The following is a description of a gene set: from publication Lund R, Aittokallio T, Nevalainen O, Lahesmaa R (PMID 14607935) Th1 and Th2 cells arise from a common precursor cell in response to triggering through the TCR and cytokine receptors for IL-12 or IL-4. This leads to activation of complex signaling pathways, which are not known in detail. Disturbances in the balance between type 1 and type 2 responses can lead to certain immune-mediated diseases. Thus, it is important to understand how Th1 and Th2 cells are generated. To clarify the mechanisms as to how IL-12 and IL-4 induce Th1 and Th2 differentiation and how TGF-beta can inhibit this process, we have used oligonucleotide arrays to examine the early polarization of Th1 and Th2 cells in the presence and absence of TGF-beta after 0, 2, 6 and 48 hours of polarization. species: Homo sapiens Human Gene Set: GSE2770_IL4_ACT_VS_ACT_CD4_TCELL_2H_DN Genes down-regulated in CD4 T cells activated by anti-CD3 and anti-CD28: IL4 (2h) versus untreated (2h)., and this is the list of marker genes: LARP1, AHCTF1, HECTD2, INPP5A, SELENON, CLIC4, ZDHHC23, RNF111, CFAP70, SLC16A1 (solute carrier family 16 member 1), VSIG10L, TTLL11, PER1, F3, CFAP141, PPP1R15B, NMD3, PARVG, DNAJC21, CHAMP1, ZBTB2, ARAP2 (ArfGAP with RhoGAP domain, ankyrin repeat and PH domain 2), FAM241A, MFSD2A, FILIP1L, POGK, PTPN1, ARHGEF3, PLCXD2, CALCRL, MTHFR, RYBP, ADAR (NCBI Gene Id 3427), TAMALIN, SRSF11, NR4A3, CRY2, CHD7, ITPKC, USP31, IFRD1, CDV3, KPNB1, ICAM1, TRAF3, SPRTN, TRIM44, ARL14EP, AFMID, GPR183, TRMT6, CGAS, ZNF131, TIMM8A (NCBI Gene Id 84782), OAS2, MAPKAPK2, VPS54, DDX3X, KCNE1, AHCYL1, UPF3A, P2RX4, JAKMIP2, PPP1R15A, RABEP1, SESN2, HNRNPU, SLC41A1, PA2G4, ERLIN1, LCP2, ABHD17C, ZEB1 (NCBI Gene Id 6935), SLAMF7, LRRC3B, ZHX2, FARSB, PGS1, TREML2, GOLGA5, AXIN1, RIOX1, KHDC4, GABRP, NFE2L1, SLC23A2, NOP14, GPR146, SRSF10, EIF3D, CD300LF, ALDH18A1, ATP8B4, NDFIP1, BTG1, CARS1, RELB, TTC39B, NAT10 (NCBI Gene Id 79715), SEC63, EIF2S2 (NCBI Gene Id 9359), LIPG, SLC38A2, BHLHE40, TOP1MT, LGALS3BP, HUWE1, METTL2B, MTMR12, TDRD12, ESF1, SLC25A33, ARIH2, HGH1, MNT, AKAP10, LONRF1, PLSCR1, IKZF4 (IKAROS family zinc finger 4), NAB1, TUT7, TMTC2, CYP21A1P, CD200, FOXN2, TMEM209, ATP11B, PTAR1, CISH, TSC22D2, TAP2, NECAP1, LPP, MAP2K4, PVT1, GIMAP8, GYS1, AOC3, AHI1, PFKP, PELI1, RBM15B, STK40, UBE2G2, WDR77, XPO6, COL7A1, SELENOI, SLC1A5, DBT, RNF149, MID1IP1, ELL, USP22, MAML1, SLC25A51, JAK2, DDX11, SLC66A2, PDZD8, IARS1, CBLB, RAPGEF6, POU5F1, TBPL1, NLRC5, SLC14A1, JUNB, IL6ST, ITPRID2, MTHFD1L, CATSPERD, PHF10, NOL8, PLCL1, CPSF6 (NCBI Gene Id 11052), NFKB1, AKAP14, MORC2, PLEK, PARP6, ATF3, SLC7A5, SLFN12, USP36, ATF6, CDC25A, NFKBID, MAP3K14, MGAT1, PRPF38B, KLHL24, BAZ1A (bromodomain adjacent to zinc finger domain 1A), ST6GALNAC6, AQP1, PHF13, ASNS, BLTP1, TAPBPL, BEND3